Given this list of marker genes ALG1, here is a description of the gene set: Reactome Pathway: Defective ALG1 causes CDG-1k studied in species Homo sapiens part of: Diseases associated with N-glycosylation of proteins Chitobiosyldiphosphodolichol beta-mannosyltransferase (ALG1) normally tranfers a mannose moiety to the lipid-linked oligosaccharide (LLO aka N-glycan precursor) which is required for subsequent N-glycosylation of proteins. Defects in ALG1 can cause congenital disorder of glycosylation 1k (ALG1-CDG, previously known as CDG1k; MIM:608540), a multisystem disorder characterised by under-glycosylated serum glycoproteins. CDG type 1 diseases result in a wide variety of clinical features, such as defects in the nervous system development, psychomotor retardation, dysmorphic features, hypotonia, coagulation disorders, and immunodeficiency. Compared to other CDGs, ALG1-CDG has a very severe phenotype, which can result in an early death.